The following is a description of a gene set: Human Gene Set: GOBP_REGULATION_OF_FEAR_RESPONSE studied in species Homo sapiens Any process that modulates the frequency, rate or extent of fear response., and this is the list of marker genes: UCN, EPHB2, GRP, PRKAR1B, GRPR, APOE, CRH (corticotropin releasing hormone), MEF2C, RAG1, NPAS2, PENK